Given this list of marker genes EIF3I, CD82, HSPB1, AP2M1, CHN1, SPOCK2 (NCBI Gene Id 9806), PARK7, SNX9, TBC1D4, UCP2, TNFRSF18, TNFRSF4, TIGIT, DUSP4, CRTAM, PEBP1, CCR7 (NCBI Gene Id 1236), CORO1B, PGAM1, FKBP5, BBLN, PMAIP1, KLRB1, GEM, BIRC3, STAT3 (signal transducer and activator of transcription 3), LTB, GBP2, CNIH1 (cornichon family member 1), ARID5B, IL6ST, PKM, RBPJ, ITM2A, NFKBIA, DNPH1, MAGEH1, CXCL13, CTLA4, ICA1, FKBP1A, BATF, GPX4, ICOS, NR3C1 (NCBI Gene Id 389335), CD27, IL7R, MAF, IGFLR1, TNFRSF9, here is a description of the gene set: Human Gene Set: GAVISH_3CA_METAPROGRAM_CD8_T_CELLS_DYSFUNCTION In this study, an extensive analysis was conducted to define meta-programs (MPs) capturing intra-tumor heterogeneity across a spectrum of tumor types. The approach utilized non-negative matrix factorization (NMF) to analyze each cell type separately within individual tumor samples. This involved the analysis of malignant cells, macrophages, fibroblasts, endothelial cells, epithelial cells, T-cells, and B-cells. NMF was executed with varying parameter values (K=4, 5, 6, 7, 8, 9), thereby generating 39 programs for each cell type per sample. Each NMF program was summarized by the top genes based on NMF coefficients.\nRobust MPs were then delineated for each cell type using a set of stringent criteria, including recurrence within the same tumor, similarity to programs in other tumors, and non-redundancy within a tumor. Subsequently, these robust NMF programs were clustered (per cell type) based on Jaccard similarity, leading to the identification of MPs associated with each cell type.\nTo enhance the quality of the MPs, a refinement steps were undertaken, involving the removal of MPs suspected of reflecting low-quality data (with an overrepresentation of ribosomal proteins or mitochondrial-encoded genes), single-study inclusion, or similarity to miss-annotated cell types. Genes upregulated in subsets of cells of a given type within various tumors studied in species Homo sapiens from publication Gavish A, Tyler M, Greenwald AC, Hoefflin R, Simkin D, Tschernichovsky R, Galili Darnell N, Somech E, Barbolin C, Antman T, Kovarsky D, Barrett T, Gonzalez Castro LN, Halder D, Chanoch-Myers R, Laffy J, Mints M, Wider A, Tal R, Spitzer A, Hara T, Raitses-Gurevich M, Stossel C, Golan T, Tirosh A, Suvà ML, Puram SV, Tirosh I (PMID 37258682)